The following is a description of a gene set: from publication Fu W, Ergun A, Lu T, Hill JA, Haxhinasto S, Fassett MS, Gazit R, Adoro S, Glimcher L, Chan S, Kastner P, Rossi D, Collins JJ, Mathis D, Benoist C (PMID 22961053) The transcription factor FoxP3 partakes dominantly in the specification and function of FoxP3+ CD4+ T regulatory cells (Tregs), but is neither strictly necessary nor sufficient to determine the characteristic Treg transcriptional signature. Computational network inference and experimental testing assessed the contribution of several other transcription factors (TFs). Enforced expression of Helios or Xbp1 elicited specific signatures, but Eos, Irf4, Satb1, Lef1 and Gata1 elicited exactly the same outcome, synergizing with FoxP3 to activate most of the Treg signature, including key TFs, and enhancing FoxP3 occupancy at its genomic targets. Conversely, the Treg signature was robust to inactivation of any single cofactor. A redundant genetic switch thus locks-in the Treg phenotype, a model which accounts for several aspects of Treg physiology, differentiation and stability. studied in species Homo sapiens Human Gene Set: GSE40274_EOS_VS_FOXP3_AND_EOS_TRANSDUCED_ACTIVATED_CD4_TCELL_DN Genes down-regulated in CD4 T conv over-expressing: IKZF4 versus IKZF4 and FOXP3., and this is the list of marker genes: PCDH8 (protocadherin 8), IFNL2, SMR3A (submaxillary gland androgen regulated protein 3A), STK35 (NCBI Gene Id 140901), TCF7L1, B3GALNT1, PON1, CSNK1G1, MUC16, MIR421, AKR1D1, MIR379, PPP1R27, IL17D, HCRTR2, NFIB, MIR377, H2BC21, CSPG5, SYT8, SLC25A48, SPAG17, ITIH2, MAFG, PLXNA4, PON3 (paraoxonase 3), FAM170A, PILRA, PHYHD1, SPOCD1, ARVCF, LHFPL5, FRMD7, ANO1, GH1, GLRA3, FBLL1, NKX2-6, ZIK1, SOHLH1, ENAH, MS4A1, VSX2, KLHL32, CASKIN1, GNG3, ADARB2, TTC36, DUSP3, CC2D2A (coiled-coil and C2 domain containing 2A), LRRC52, SLC7A2, LRRC8B, PPFIBP2, FRMPD4, SUPT3H, KIRREL2 (NCBI Gene Id 84063), SLC16A10, KCNK18, ALDH3A1, GRHL2, RBMS3, IGF2BP3, CRACR2B, TCAF2, PDYN, TBC1D2, CYP11B1, IQCA1, FAM117A, NOSTRIN, HSPB3, PAX2, LTK, KDM5C, STXBP1, SPTLC3, TCTN2, SOX21, RASSF9, ALPG, CES5A, TRPV3, SGPP2, BATF2, RAG2, NRAS, PELI2, GABRR2, RESP18, CYP7B1, XIST, SPAG16, TMEM201, MFAP3L (microfibril associated protein 3 like), NRXN2, ZCCHC12, CNIH2, GDF15, NUDT12, LHX6, AURKA, FUT4, TAAR3P, PAMR1, SLCO1C1, GRP, CHMP4C, TDO2, MASTL, GLI1, NICN1, PRUNE2, KCNA1, CC2D2B, MCTP1, MAPK7, AQP6, ACTL6B, NR2E3, CER1